Given this list of marker genes Bak1, Septin4, Cycs, Bax, Gsdmd, here is a description of the gene set: This event has been computationally inferred from an event that has been demonstrated in another species.<p>The inference is based on the homology mapping from PANTHER. Briefly, reactions for which all involved PhysicalEntities (in input, output and catalyst) have a mapped orthologue/paralogue (for complexes at least 75% of components must have a mapping) are inferred to the other species. electronically inferred by orthology from the curated human pathway Reactome Pathway: Release of apoptotic factors from the mitochondria species: Mus musculus part of: Apoptotic factor-mediated response